The following is a description of a gene set: An abnormality of tracking eye movements in which smooth pursuit is interrupted by an abnormally high number of saccadic movements. Human Gene Set: HP_SACCADIC_SMOOTH_PURSUIT Saccadic smooth pursuit species: Homo sapiens, and this is the list of marker genes: SCYL1, GJB1, ANO10, UCHL1, SPG11, RFC1, ATN1, PIK3R5, PMPCA, TPP1, ZFYVE26, ALS2, ATP2B3, CACNA1A, CACNA1G, STUB1, RNF170 (ring finger protein 170), TMEM106B, RUBCN, KCND3, FMR1, SETX, XRCC1, PRKCG, TMEM240, PRDX3 (NCBI Gene Id 29017)